Given this list of marker genes Cyp3a13, Pon1, Abcc2, Cyp3a11, Cyp3a25, Cyp3a44, Cyp3a41b, Pon3, Cyp3a41a, Cyp3a57, Ugt1a5, Cyp3a16, here is a description of the gene set: studied in species Mus musculus part of: Drug ADME This event has been computationally inferred from an event that has been demonstrated in another species.<p>The inference is based on the homology mapping from PANTHER. Briefly, reactions for which all involved PhysicalEntities (in input, output and catalyst) have a mapped orthologue/paralogue (for complexes at least 75% of components must have a mapping) are inferred to the other species. electronically inferred by orthology from the curated human pathway Reactome Pathway: Atorvastatin ADME